Given this list of marker genes Rps9, Rpl8, Rpl6, Rpl19, Rps13, here is a description of the gene set: Binding to 5.8S ribosomal RNA, a eukaryotic ribosomal RNA which forms a complex with 28S RNA. species: Mus musculus Mouse Gene Set: GOMF_5_8S_RRNA_BINDING